The following is a description of a gene set: Mouse Gene Set: GOBP_RESPONSE_TO_PROTOZOAN species: Mus musculus Any process that results in a change in state or activity of a cell or an organism (in terms of movement, secretion, enzyme production, gene expression, etc.) as a result of a stimulus from a protozoan., and this is the list of marker genes: Irf4, Gm12250, Trbv13-3, Igtp, Il12a, Il4ra, Tlr12, Spn, Il6, Nras, Cd40, Iigp1, Cd37, Tgtp2, Vtcn1, Gbp6, Myd88, Irgm2, Pf4 (platelet factor 4), Gbp10, Slc11a1, Gbp4 (guanylate binding protein 4), Il4, Gbp7, Gbp3, Bcl3, Batf2, Arg1, Gbp2b, Gbp9, Batf, Il10, Hras, Gbp2 (guanylate binding protein 2), Ccdc88b, Bpgm, Tspan32, Enpp1, Ier3, Ifng, Nkg7, Tgtp1, Lyst, Il12b, Irf8 (interferon regulatory factor 8), Gbp8 (NCBI Gene Id 76074)